The following is a description of a gene set: studied in species Mus musculus from publication Cui A, Huang T, Li S, Ma A, Pérez JL, Sander C, Keskin DB, Wu CJ, Fraenkel E, Hacohen N (PMID 38057668) Cytokines mediate cell-cell communication in the immune system and represent important therapeutic targets. A myriad of studies have highlighted their central role in immune function, yet we lack a global view of the cellular responses of each immune cell type to each cytokine. To address this gap, the authors created the Immune Dictionary, a compendium of single-cell transcriptomic profiles of more than 17 immune cell types in response to each of 86 cytokines (>1,400 cytokine-cell type combinations) in mouse lymph nodes in vivo. A cytokine-centric view of the dictionary revealed that most cytokines induce highly cell-type-specific responses. For example, the inflammatory cytokine interleukin-1β induces distinct gene programmes in almost every cell type. A cell-type-centric view of the dictionary identified more than 66 cytokine-driven cellular polarization states across immune cell types, including previously uncharacterized states such as an interleukin-18-induced polyfunctional natural killer cell state. Mouse Gene Set: CUI_T_CELL_GD_IL13_RESPONSE_DN Genes negatively differentially expressed in cell type: γδ T cell upon treatment with cytokine: IL-13 in mouse lymph nodes in vivo., and this is the list of marker genes: Nr4a1, Klf6, Hspa1b, Dusp1, Fos, Jun, Ppp1r15a, Dnaja1, Junb, Hspa1a, Jund, Pnrc1, Btg2